Given this list of marker genes Afdn, Gpr137c, Apc, Dennd4a, Ppp1r3c, Dmxl1, Etf1, Taf3, Lrp2, Lysmd3 (NCBI Gene Id 80289), Ntng1, Ppp3ca, Arih1, Tmem163, Klhl28, Fat2, Tmpo, Adarb1, Kras, Ncoa1, Tor1aip2, Arhgap12, Usp21, Has2, Stim2 (NCBI Gene Id 116873), Myt1l, Creb1, Thsd7a, Gpr34, Sec23a, Cpne8, Erbin, Elk3, Zfp36l2, Pdgfra, App (amyloid beta precursor protein), Lpgat1, Ctnnd1, Gls, Stradb, Sertad2, Ino80, Golm2, Tmprss2, Sowahc, Tjp1, Appl1, Cnot7, Fgd6, Yy1, Ctcf, Grip1, Zmynd11, Cdc37l1, Fubp1, B4galt6, Mycn, Pogz, Proser1, Smarca5, Hdx, Sash1, Pik3c2a, Bbx, Sobp, Cadm2, Ctsc, Foxg1, Cdk6, Msl1, Rbbp7, Pdcd11, Rnf145 (ring finger protein 145), Maml3 (mastermind like transcriptional coactivator 3), Xrcc4, Mageb4, Rabgap1l, Dpysl2, Dock3, Zfhx4, Camk2d, Ythdc1, Tbc1d8b, Fsd1l, Gpd2, Pde7a (phosphodiesterase 7A), Acsl4, Nfkb1, Csmd3, Vmn2r28 (vomeronasal 2, receptor 28), Crispld1, Epha7, Ppp2r5a, Smim15, Ubr3, Zfp750, Sorbs1, Hook3, Zfp704, Psme4, Smoc1, Crim1, Gnai1, Spopl, Ssx2ip, Nabp1, Dusp19, Fam76b, Prcp, Vps29, Zc3h6, Socs3, Cacna2d1, Asap2, Arpp19, Lhx8, F3, Ipo8, Zeb2, Caap1, Klhl9, Tmem87a (transmembrane protein 87A), Zcchc8, Neurog3, Sirt1, Kpna2, Hnrnpl, Sos1, Clock, Dnajb5, Esp31, Atxn1, Stap1, Hectd2, Reep3, Bcat1, Lats1, Ikzf2, Zfp354a, Pparg, Lmo4, Cyth3, Sall3, Rb1, Csnk1g1, Ifit1bl2, Atad2, Tcea1, Ercc6l2 (excision repair cross-complementing rodent repair deficiency, complementation group 6 like 2), Ptprj (protein tyrosine phosphatase receptor type J), Sh3gl3, Ski, Hnrnph2, Mex3d, Spty2d1, AI593442, Osbp, Ctso, 4930444P10Rik, Kmt2c, Tnrc6b, Rybp, Ubr5, Yipf2, Gab1, Tmcc1, Hnf1a (HNF1 homeobox A), Mecp2, Topors, Rdx, Sgpl1, R3hdm1, Dmrta1, Lima1, Gpc4, Nufip2, Garre1, Runx1, Creb5, Tdp1, Mier3, Ulk2, Scai, Mdga2, Rasgef1a (RasGEF domain family, member 1A), Skil, Taf2, Zdhhc21, Mcf2, Zc3h12c, Msi2, Tbcel, Pbrm1, Sar1b, Ap3m2, Reps2, Wdr26, Slain2, Ube2k, Chic1, Vezf1, Gpm6a, Ppp2r2a, Pabpc5 (NCBI Gene Id 93728), Clec4e, Ube2q2, Cul4b, Rps6ka5, Xk, Sh3bp4, Zfp605 (zinc finger protein 605), Ctnnb1, Ctsq, Nxpe2, Castor1, Map3k12, Bmpr2, Tmprss11f, Mknk2, Col3a1, Fyttd1, Tceal7, Phip, Maml1, Cenpw, Fam199x, Ppp3r1, Zbtb34, Erlin2, Brd4, Pcgf5, Sgip1, Rab5c, Adgrb3, Desi2, Wiz, Trim2, Chd1, Slc5a7, Ppm1e, Neo1, Gramd4, Ap1s2, Kif5b, Hipk3, Gask1b, Ppp1r1c, Pcdhb18, Ptbp3, Zfp236, Ube3c, Gjd4, here is a description of the gene set: Genes predicted to be targets of miRBase v22 microRNA mmu_miR_3473g in miRDB v6.0 with MirTarget v4 prediction scores > 80 (high confidence targets). species: Mus musculus Mouse Gene Set: MIR_3473G from publication Chen Y, Wang X (PMID 31504780)